Given this list of marker genes Mapt, Dbn1, Apc, Myo9a, Shtn1, Mapk8ip1, Dynlt1f, Boc, Kif21a, Hdac5, Nrxn1, Taok2, Hsp90aa1, Dynlt1a, Scn11a, Trak2, Lrp2, Flna, Dynlt1b, Trak1, Trpv2, Agrn, Olfm1, L1cam, Pard6a, Pard3, Kif5b, Tiam1, Fkbp4, Cyfip1, Snap25, Dynlt1c, Clasp2, Rtn4r, Nin, Palld, Kif5c, Limk1, Hsp90ab1, Epha4, Lrp1, Ptch1, C9orf72, Cobl, Gpm6a, Flrt3, Smo, here is a description of the gene set: The migrating motile tip of a growing nerve cell axon. studied in species Mus musculus Mouse Gene Set: GOCC_AXONAL_GROWTH_CONE